The following is a description of a gene set: Genes having at least one occurrence of the motif GGGGGTTGACGYANA in the regions spanning 4 kb centered on their transcription starting sites. This matches the transcription factor binding site V$TAXCREB_01 (v7.4 TRANSFAC). studied in species Homo sapiens Human Gene Set: TAXCREB_01, and this is the list of marker genes: FGF14, NR4A3, ZNF516-DT, SMARCA5, SIX3, DUSP1, ARMCX3, KIF7, DLAT, MBNL2, TAGLN2, JUND, XPR1, PLK4, CD2AP, PPP2CB, GPC6, GEM, HAS1, MARCHF6, ZNF644, PTPRU, FAM117B, GTF2A1, GPM6B, KDM3B, SMIM19, NR2F1 (nuclear receptor subfamily 2 group F member 1), TFIP11, OSR1, GPR3, SDHB, TRAPPC10, TRIM39, SHANK2, NINJ1, KLF13, G6PC1, TLNRD1, LUC7L2 (NCBI Gene Id 51631), NTRK2, CORO6, PHF20L1, CAMK2D, MLF2, CDC42, ARIH1, VAMP2, HOXB1, MARCKS, BAHD1, SCAMP5, TMUB2, FAM131A, ZBTB7A, PEG3, RAB37, GATA1, SMARCD1, EIF4A2, RFX5, MAP1LC3A, KDELR3, TAPT1, TAPT1-AS1, NLK, OTUB2, GSPT1, VEGFA, CLSTN3, CTCF, HS6ST2 (heparan sulfate 6-O-sulfotransferase 2), DNAJB2, PHF12, RBP5, CYLD, VGF, SRSF1, PRMT3, HOXA10, JADE3, HHIP, PLCB3, ATF1, CDKN1B, TSPAN7, PNRC1, SOX10, LINC00671, CEBPB (NCBI Gene Id 90277), KLF9, VEZF1, PAMR1, APPBP2, TAF11, TMEM59L, KCNT2, PAK1, GLYR1, FOS, OSBP, CDK5R2, POLDIP3, ANKS1A, MAGI1, C11orf87, ARRB2, DAGLA, TUBA3C, BNIP2, FOSB, TUT1, RPS27, PCF11, NOL4, NSD3, ASXL1 (NCBI Gene Id 23393), SLC25A5, BRAF, CCND2, USP14, RUNDC3A, CALM2, DLST, IRF2BPL, GPR158, SIK1, TSC22D2, ZIM2, LMO4 (LIM domain only 4), PAFAH1B1, SLC30A5, SSTR3, RING1, ZFY, MAFF, TM9SF3, KDM2A, DLX5, IRX4